The following is a description of a gene set: Mouse Gene Set: THRB_TARGET_GENES Genes containing one or more binding sites for (Thrb) in their promoter regions (TSS -1000,+100 bp) as identified by GTRD version 20.06 ChIP-seq harmonization. from publication Yevshin I, Sharipov R, Kolmykov S, Kondrakhin Y, Kolpakov F (PMID 30445619) studied in species Mus musculus, and this is the list of marker genes: Apobec1, Tle6, Asb15, Gm9530, Ado, 5430435K18Rik, Uck1, C2cd5, Gpr146, Trp53inp2, Mafk, Camk2b (NCBI Gene Id 12323), Gm16253, Dbp, Lpin3, Adcy7, Gpcpd1, Gm15722, Gbp3, Ppat, A930012O16Rik, Rel, 0610012D04Rik, Cyb561, Izumo1, Usp32, Ino80e, Cggbp1, Rab7b, 9630013D21Rik, Cldn12, Ighv1-62 (NCBI Gene Id 677643), Jun, Mir1931, Sfi1, Chd3, Hsf1, Tmem267, Wfdc11, Dnai1, Hip1, Bop1, Msh3, Gm829, Gm6610, Rrp12, Paics, Alkbh7, Pmm2, Kmt5c (NCBI Gene Id 232811), Them6, Cacnb3, Junos, 9330154K18Rik (NCBI Gene Id 319829), Gm14206, Yju2b, Ubc, Cdc42ep1, Neat1, Dhx8, Gm40117, Tcirg1, Nt5e, mt-Nd6, Zfp677, Gm12349, Dot1l, Pik3r2, Schip1, mt-Tt, Gm17748 (predicted gene, 17748), Ap3m1, Sertad2, Dpf2, Dab2, Lhfpl2, Gm10222, Ulk2, mt-Tp, Acox2, Ndufa5 (NCBI Gene Id 68202), Decr1, Tnfaip2, Pgk1, Coa5, Irak2, Cd47, Unc50, Susd6, Dennd4b, Ank1, Rrn3, Rin2, Hif1a, Mir7008, 3110070M22Rik, Rab34, Mfsd6 (major facilitator superfamily domain containing 6), Nsun3, Eif4g1, Gm8357, Lgi4, 5031425E22Rik, Gbe1, Gm6658, Dhrs7, Ankrd35, Ap1s2, Gm15564, Adam17, Gatad2a, Robo3, Hirip3, mt-Te, Bbc3, Slc44a1, Tmem186, Thra, Kmt2e, Arhgap23, Gpd2, Tead4, Sirt2, Tbcel, 1700113A16Rik, Fam219a